The following is a description of a gene set: Human Gene Set: GOBP_LUTEINIZING_HORMONE_SECRETION studied in species Homo sapiens The regulated release of luteinizing hormone, a gonadotropic glycoprotein hormone secreted by the anterior pituitary., and this is the list of marker genes: OPRK1, FOXL2, CGA, FOXD1, SMAD4, CRH, TMF1, TBX3, TACR2, LEP